Given this list of marker genes ITPKA, RCSD1, SLAMF6, NAMPT, DDRGK1, CTSS, RILPL2, ZRANB2, LYRM2, DDB2, ETFB, ACSF3, ADGRE5, MRPL16, TRAF5, B3GNT2, GLCE, PRR15, C15orf40, TMC4, SLC39A11, EBAG9, TMEM128, HAUS5, C1orf174, CADM1, MARK3, FAM81A, OSGIN2 (NCBI Gene Id 734), NOL7, ID3, DAB2IP, DIABLO, BTG1, DMD, XCL1, CHCHD7, NR3C1, ITGB1, GLOD4, CHST15, AATK, PARP9, LMAN1, RASGRP1, UQCR10, ZC3HC1 (NCBI Gene Id 51530), PWP1, CBX4, MRPS14, TP53BP1, CNOT3 (NCBI Gene Id 9756), SFI1, HMGCS1, STAT4 (signal transducer and activator of transcription 4), HLA-DOA, HIBCH, RAP2B, MED16, LRATD1, SMIM19, LRR1, ZNF277, SPIN4, EXOC6, ENO3, PKP2, HMGXB4, B3GNTL1, TCEA2, CRYL1, ETFRF1, UBIAD1, TSPAN14, PHTF2, IRF1, FAS, MRPS11, MRPS34, SMIM11, TCEA1, RBMX, OC90, CD81, NUDT5, RFC5, SNRK, NUP42, TDRP, GPHN, H2AZ1, CELF2, CASP3, SHISA5, PNPLA6, PTPN11, MRPL49, PNPT1, TEFM, CMPK1 (NCBI Gene Id 51727), MLST8, MDFIC, NUDT14, ZNF566, DUSP2, ADIPOR2, THYN1, ASF1A, ITK, MIF, SOSTDC1, ZNF106, NUDT19, FAM53A, SYNJ2BP, APAF1 (apoptotic peptidase activating factor 1), PIK3CD, RHBDL3, ECI1, LACTB, PSMA1, BCKDHB, STX17, ARHGEF3, APPL2, CHD6, PRICKLE1, M6PR, PVT1, MBNL1, TNFSF8, HLA-B, PTS, SLAMF7 (NCBI Gene Id 57823), MRPL39, RUVBL1, NDUFS8, MYO18A, TAPBPL, HERC4, NRDE2, HIVEP3, HIP1R, ATP9B, RNF167 (ring finger protein 167), GALNT10, KCTD1, HDDC2, EIF4G3 (eukaryotic translation initiation factor 4 gamma 3), GYPC, COQ9, ATF7IP, DDX10 (DEAD-box helicase 10, NCBI Gene Id 1662), ITGA4, ENPEP, CFAP298, DENND2D (DENN domain containing 2D), PSMA7, GNB1L, SYCP1, CD96, PRKD3, TMEM192, CHEK2, IFI30, C8orf82, VRK2, HAUS1, ELK4, GTPBP1, CCL1, YIPF5, NRL, DYM, SDHD, TNFRSF18 (TNF receptor superfamily member 18), PSME1, SAP18, ADSL, KARS1, SOCS4, C2CD3, MTBP (NCBI Gene Id 27085), PSMG1, HSPBP1, THAP4, SYNE2, POU2F2, WDR26, SIDT1 (NCBI Gene Id 54847), TUBD1, COMTD1, UGDH, FOXRED1, ITIH5, TSPAN3, PCNA, SENP2, NCOA2, ANAPC1, here is a description of the gene set: from publication Ng SY, Yoshida T, Zhang J, Georgopoulos K (PMID 19345118) Human Gene Set: GSE15330_WT_VS_IKAROS_KO_GRANULOCYTE_MONOCYTE_PROGENITOR_UP Genes up-regulated in granulo-monocyte progenitors: wildtype versus IKZF1 knockout. Regulation of lineage potential and transcriptional priming by Ikaros. New insight is provided into a bivalent regulation of lineage priming in the HSC and its lympho-myeloid restricted progeny the LMPP by the lymphoid lineage-determining factor Ikaros Whereas Ikaros is responsible for the activation of a cascade of lymphoid expression programs and for the establishment of lymphoid potential from the HSC to the LMPP it is also responsible for the repression of stem cell and erythroid genetic programs that are incompatible with further lineage restrictions emanating from the LMPP studied in species Homo sapiens